Given this list of marker genes Pdha1, Dlat, Dld, here is a description of the gene set: part of: Pyruvate metabolism Reactome Pathway: PDH complex synthesizes acetyl-CoA from PYR This event has been computationally inferred from an event that has been demonstrated in another species.<p>The inference is based on the homology mapping from PANTHER. Briefly, reactions for which all involved PhysicalEntities (in input, output and catalyst) have a mapped orthologue/paralogue (for complexes at least 75% of components must have a mapping) are inferred to the other species. electronically inferred by orthology from the curated human pathway studied in species Mus musculus